The following is a description of a gene set: Mouse Gene Set: GOBP_RESPONSE_TO_MUSCLE_ACTIVITY_INVOLVED_IN_REGULATION_OF_MUSCLE_ADAPTATION studied in species Mus musculus Any process that results in a change in state or activity of a cell or an organism (in terms of movement, secretion, enzyme production, gene expression, etc.) as a result of a muscle activity stimulus. This process occurs as part of the regulation of muscle adaptation., and this is the list of marker genes: Agt, Selenon, Prkag3, Srl, Myog